The following is a description of a gene set: species: Mus musculus Catalysis of the hydrolysis of a peptide bond not more than three residues from the N- or C-terminus of a polypeptide chain, in a reaction that requires a free N-terminal amino group, C-terminal carboxyl group or both. Mouse Gene Set: GOMF_EXOPEPTIDASE_ACTIVITY, and this is the list of marker genes: Dpp6, Matcap1, Rnpepl1, Ctsl, Cpb1, Trhde, Lap3, Folh1, Agbl2, Dpep1, Dpep3, Cndp2, Mmp16, Erap1, Naaladl1, Lnpep, Vash2, Ctsa, Mme, Rnpep, Cndp1, Agtpbp1, Matcap2, Dpp10, Ace, Lta4h, Ermp1, Gpc3, Tpp2, Cpa4, Dnpep, Scpep1, Agbl3, Npepps, Cpb2, Cpa2, Dpp3, Blmh, Cpn1, Dpp8, Ctsz, Prcp, Scrn3, Jmjd7, Actmap (NCBI Gene Id 434154), Cpe, Mindy1, Hpn, Cpa5, Cpm, Nudt16, Naalad2, Adam17, Dpp7, F11, Cpa3, Adam10, Dpp4, Kdm8, Dpp9, Cpvl, Enpep (NCBI Gene Id 13809), Mindy2, Agbl5, Dpep2, Mmp14, Atg4d, Pm20d2, Xpnpep3, Npepl1, Aebp1, Rce1, Metap2, Cpxm2, Anpep, Metap1, Xpnpep1, Metap1d, Cpz, Scrn2, Xpnpep2, Prep, Scrn1, Vash1, Cpd, Pepd, Aopep, Agbl4, Ctsc, Prss16, Mep1a, Cpxm1, Tpp1, Cpa1, Fap, Agbl1, Ctsh, Cpq, Ace2, Cpa6, Ace3